Given this list of marker genes Taldo1, Rbks, Rpia, Dera, Shpk, Prps2, G6pdx, Pgm2, Pgd, Rpe (NCBI Gene Id 72761), Prps1l1, Pgls, Prps1, Tkt, Prps1l3, here is a description of the gene set: Mouse Gene Set: REACTOME_PENTOSE_PHOSPHATE_PATHWAY Pentose phosphate pathway studied in species Mus musculus